The following is a description of a gene set: Any functional anomaly of the pumonary valve. Human Gene Set: HP_ABNORMAL_PULMONARY_VALVE_PHYSIOLOGY studied in species Homo sapiens Abnormal pulmonary valve physiology, and this is the list of marker genes: WASHC5, RAB23, STRA6, DDX3X, ATP11A, RAP1B, TBX1, MAP3K7, ZNF341, COL1A1, VPS35L, SMAD4, RAD21, CREBBP, AGO2, CUL3, EP300, HRAS, CCNQ, PGAP1, FLNA, SMAD2, MAP2K2, CHD3, RTEL1, STX1A, NOTCH2, ADK, RIT1, GTF2I, TMEM270, GDF1, BUD23, CCDC22, FLT4, ENPP1, MUC5B, GATA6, GNPTAB, ZNF469, STN1, SOS2, METTL27, POLR3A, CIC, LRP4, MGP, TBL2 (NCBI Gene Id 27203), EFEMP2, COL1A2, INVS, BCOR, ZIC3, SPRED1, GTF2IRD1 (GTF2I repeat domain containing 1, NCBI Gene Id 9569), CHST3, SOS1, FBN1, VPS37D, SFTPA2 (NCBI Gene Id 83342), NEK9, FAM13A, FOXF1, PSMD12, MAP2K1, LIMK1, EIF4H, WAC, CDC42, KCNH1, SMAD3, B4GALT7, NCF1, NOTCH1, SMAD6, SMC3, SMC5, DCHS1 (dachsous cadherin-related 1), BUB1B, ZNF699, BMP2, GPC3, KIF20A, PTPN11, DSG1, DNAJC30, RNF135, TERC, ADAMTS19, LTBP2, TERT, TBCK, GTF2IRD2, B3GLCT, SKIC3, MLXIPL, RAF1, COL3A1, OTUD5, ADAMTS17, CHD7, HIVEP2, ZEB2, DAW1, PPP1CB, SGO1, PRDM5, NIPBL, BRAF, WNT4, DNAL1, ANKS6, FKBP6, GATA4, KAT6A, PLD1, NEK8, ARPC4, ADAMTS10, NF1 (NCBI Gene Id 646021), PARN, TRAF7, SHOC2, SFTPC, NRAS, IGFBP7, SLC29A3, FAT4, DSP, CLIP2, ABCA3, MRAS, SFTPA1, RPL27, FBXW11, GPC4, ADA, BAZ1B, ELN, ARSB (NCBI Gene Id 411), NKX2-6, RFC2, DPYSL5, LZTR1, KDM6A, TBX2, NRXN1, CCDC32, KANSL1, G6PC3, KRAS, ITPR1, SMARCA4, BPTF, DPP9, PLXND1, ACAD8, TBX5, SARDH, CIROP, SPRED2, FKTN, LEMD2, ARHGAP31